Given this list of marker genes SGO2, MAPK6, H2AC7, PPP2R2A, NAALADL2, GARNL3, NXN, EPS8, CLNK, ITGB5, SPATS2L, SEMA3C, RNU6-1301P, SYTL5 (NCBI Gene Id 94122), RPS27L, FOXD1-AS1, CFDP1, UQCRH, SPINK5, PRDM1, LINC01588, PSME2P3, NPM1, ARRDC3-AS1, ACAA1, TNRC18, CASD1, IGFL2-AS1, GCNT3, HSD17B2, LINC02889, RNF125, PDHX, REG4, LAMA3, NOD1, PGM3, LRRC1, SPRED2, SUMF2, TSPAN8, SH2D5, LMO7, GLRX, C1orf105, DNMBP (NCBI Gene Id 23268), ARHGAP32, JMY, VILL, MYOF, DUT, INO80, MYO10, XPNPEP1, CASP8, TMCC1, NXPE1, FERMT1, LIMA1, BCL2L15 (NCBI Gene Id 440603), IL10RB, IRS1, C1orf226, AKAP13, ASTE1, SCARA5, NASP, PURB, RAPGEF6, EML6, CIB1, DMXL2, UTRN, TMEM8B, MEF2C, SUCLA2, RAD50, PRR5L, LEKR1, WSB2, RPS27A, STARD4, AGR3 (NCBI Gene Id 155465), AGPS, ILRUN, CCDC159 (coiled-coil domain containing 159), ELL3, LINC02474, RNF186-AS1, HOXA3, RPL35A, SMIM31, RNU5D-1, LINC02453, LINC01275, RNU6-952P, NRXN1 (neurexin 1), MLLT3, PIPOX, SMAD3, KAZN, TBRG4, SPSB1, PLCB1, CFTR, PRR13P5, ATG4C, LURAP1L-AS1, ALDH18A1, TRIO, IFT46, PEX13, SEPTIN8, LINC02541, IMP4, EFCAB14, PHF12, MIR194-2HG (MIR194-2 host gene), MIR223HG, LRRC41, RNF144A, TRIM31, NME1-NME2, SMAD3-AS1, HMGN2P46, LINC01619, VCPIP1, LINC02924, ANAPC7, ZCCHC14, PRKCI, TDP2, MPZL1, LINC00511, HOXA-AS3, TMEM39A, YAE1, ADD3, HNMT, PANK3, SLC30A10, SETD5, HOXC6, ZNF217, MTIF3, LUC7L2, ATP2C1, HMOX1, NOX1, A1CF, VWA8, RAB13, CAPZA2, ENSG00000268460, GPR160, CTDSPL, MIR194-1, ARHGAP26, C17orf67, PMVK, SNORD13, ENSG00000228697, ARL14, CAP1, SLCO2B1, KHDC4, EVA1A-AS, SELENOP, HPGD, RN7SKP193, MGAM2, TTI2, ZNF106, DNAH11, AHR, CLRN3, SYNE2, PAXBP1, PIM1, CCDC192, CLIP1, MTMR11, PHYKPL, ERAP1, CDH17, RPL39P40, RN7SKP192, CEP83, DRAIC, SNORC, NXPE4, GNAL, REPIN1, RBM47, MALSU1, CCDC115, COL17A1, TERF2, PIP5K1B, POMP (proteasome maturation protein), JMJD1C, RN7SL108P, NGDN, ELOCP19, YJU2, ANK3, OAS1, RPSAP75, RPL34P1, UST-AS2, AKAP9, LINC01133, MGC32805, TMOD3, ARID5B, MBP, ZNF775, LINC00974, CASP10, MIR638, RPF1, IQCG, NR5A2, PIERCE2, ENSG00000266401, FERMT2, NME1, VMP1, VTRNA1-1, HNRNPKP5, SLC9A1 (NCBI Gene Id 6548), H2BC7, NFKBIZ, RNU4-72P, LTBP1, NWD1, CEP120, RIOK2, LINC00431, ZC3H12D, PDE4D, HINT2, TGS1, GDPGP1, FAM47E, ABCA15P, PRLR, S100A16, RGS17P1, YAP1, CDC14B, PIGC, PLAC8, SIRT4, DNTTIP2, LINC01730, RNU5E-1, PPFIBP2, ICA1, HEG1, GAPDHP25, RPL7L1P8, SRI, C1orf21, KCNK1, REXO2, ACAA2, H2BC5, LINC02253, RNF145, ELP3, DCUN1D4, VTRNA1-2, CLCN3, SCOC, LINC00365, RND3, TBL1XR1, AP4E1, EPCIP-AS1, PJA2, BCL2L14, THADA, LRRC66, SP110, MUC13, R3HDM2-DT, ENC1, TMPRSS4, SNAP23, DNM2, here is a description of the gene set: Genes containing one or more binding sites for (DLX2) in their promoter regions (TSS -1000,+100 bp) as identified by GTRD version 20.06 ChIP-seq harmonization. from publication Yevshin I, Sharipov R, Kolmykov S, Kondrakhin Y, Kolpakov F (PMID 30445619) Human Gene Set: DLX2_TARGET_GENES studied in species Homo sapiens